Given this list of marker genes PAX6, DAB1, GOSR2, PLP1, TMEM240, CCDC88C, SACS, COQ2, TPP1, ATXN1, ATXN10, ITPR1, PNPLA6, CP, SLC25A15, here is a description of the gene set: Scanning speech species: Homo sapiens Human Gene Set: HP_SCANNING_SPEECH An abnormal pattern of speech in which the words are as if measured or scanned; there is a pause after every syllable, and the syllables themselves are pronounced slowly.